The following is a description of a gene set: The chemical reactions and pathways involving glycoproteins, a protein that contains covalently bound glycose (i.e. monosaccharide) residues; the glycose occurs most commonly as oligosaccharide or fairly small polysaccharide but occasionally as monosaccharide. studied in species Homo sapiens Human Gene Set: GOBP_GLYCOPROTEIN_METABOLIC_PROCESS, and this is the list of marker genes: CHST2, APCS, MGAT1, GALNT15, B3GNT2, ALG10B, GLCE (glucuronic acid epimerase), ST6GALNAC5, ITM2B (integral membrane protein 2B), DDOST, B3GALT5, FBXO44, B4GALT2, MIR153-1, BACE2, MAN1B1, GCNT2, POGLUT1, CYTL1, MAN1A2, IGF1, RNF5, TMEM165, HEXA, AGO2, GMPPA, CTNNB1, ITM2A, MPDU1, ALG2, EDNRA, RPN2 (NCBI Gene Id 6185), BMPR1B, PTX3, CHST14, FUT8, EXT2, ST8SIA5, ALG10, ST3GAL4, ACOT8, CHST7, C20orf173, MAN2A1, DOLK, PRKCSH, B3GALT1, CRPPA, GALNT17, MARCHF6, B3GNT9, PGM3, NECAB1, NEU2, MOGS, MGAT4C (NCBI Gene Id 25834), B4GALT6, ST6GAL1, RFT1, HGSNAT, NAGLU, CHP1 (NCBI Gene Id 11261), UGGT2, CANT1, ARFGEF1, MIR101-1, DOLPP1, MIR144, MUSTN1, DPY19L1, ALG3, B4GALT5, GCNT7, ST8SIA3, TET2, TRIP11, CHSY3, XYLT1, GALNT5, FUT5, PLOD3, ST3GAL6, B3GNT3, GANAB, ABCA2, ST3GAL3, GALNT9 (polypeptide N-acetylgalactosaminyltransferase 9), POMGNT2, B3GNT7, GCNT4, TM9SF2, CELA1 (chymotrypsin like elastase 1), NGLY1, ALG11, GALNTL6, NCSTN, GALNT13, MAN1A1, ENGASE, CCDC134, C1GALT1C1, TMEM106A, ST8SIA4, ST6GALNAC1, B3GNT8, CHST1, HS3ST5, POMT2, POGLUT2, FBXO6, DERL3, GALNT3, B3GALT4, RAB1A, DPM1, TMTC1, NCCRP1, GALNTL5, TET3, PPARD (peroxisome proliferator activated receptor delta), MANBA, ALG12, BMP2, MIR147A, MGAT4A, UST, B3GAT2, RPN1, MIR520C, CHST13, B4GALT7, CHST6, MMP12, FUT7, GALNT7, GALNT18, HIF1A, HS6ST1, GALNT6, IHH, FBXO2, NUS1, TNIP1, ADAMTS12, FREY1, ST6GALNAC3, ADAMTS4, XXYLT1, B3GALT9 (NCBI Gene Id 402377), FKTN, PXYLP1, SRD5A3, NUDT14, TUSC3, MIR644A, GLB1, EXT1, ALG6, LEP, FUT11, B3GAT3, AGA (NCBI Gene Id 175), EDEM1, TMEM59, A4GNT, GANC, GATA1, POFUT2, B4GAT1, B3GNT5, GPC1, FUT6, GCNT1, PMM2, FUT4, MGAT4D (MGAT4 family member D), TMTC4, SLC2A10, B4GALNT2, DHDDS, EDNRB, MIR20A, DPAGT1, ANGPT1, ST3GAL2, B4GALT1, GOLPH3, CHSY1, SLC34A1, EDEM3, MGAT4B, BTK, FUT10, TRAK1, ALG14, KRTCAP2 (NCBI Gene Id 200185), TMEM260, TRAK2, UBE2J1 (NCBI Gene Id 51632), ST6GALNAC4, GMPPB, TCF7L2, SULF1, NECAB2, PLCB1, POFUT1, GCNT3, GALNT4, FOXL1, XYLT2, MIR17, NDST2, SYVN1, LARGE1, TRIM13, PCSK6, COG3, RXYLT1, PLOD2, B3GALT6, HPSE, HS3ST6, CCR7, GALNT8, COG7, GXYLT1, SULF2, HS3ST3B1, GOLGA2, CHST9, EXTL3, NDST1, CSGALNACT2, GAL3ST2 (galactose-3-O-sulfotransferase 2), MIR455, B3GALT2, RAMP1, CHPF (NCBI Gene Id 79586), PMM1, MGAT2, GNPTAB (NCBI Gene Id 79158), POMT1, IL33, TMTC2, TMTC3, ST3GAL1, SERP1, B3GNT6, MAN2A2, SLC35C2, RNF103, SLC35D2, GALNT14, RAB1B, FBXO27, CTSL, NAGPA, CSGALNACT1, CHST11, MGAT5B, ALG9, HS6ST3, SGSH, HS2ST1, HS3ST4, UGGT1, ST6GALNAC2, GALNT12, MIR31, MAN2B1, FUT3, IDS, NDST4, B4GALT3, RNF139, GFPT1, BMPR2, FUT2, MAGT1, MFSD8, GAL3ST1, FUT9, B3GALNT2, GNPTG, NPC1, CHST8, LARGE2, EXTL2, HS6ST2, CHST5, ADAMTS7, B3GALNT1, MIR323A, OSTC, POMK, HYAL1, VEGFB (NCBI Gene Id 7423), ITM2C, HS3ST1, PAWR, STT3A, MIR181B1, ST6GAL2, DPM3, ALG5, GAL3ST3, ERP44, PORCN (porcupine O-acyltransferase), GALNT2, CST3, PSEN1, CHPF2, MIR298, ACER2, TMEM258, ST8SIA6, CWH43, ALG8, GNS, ST8SIA2, ATP7A, CNMD, DPM2 (dolichyl-phosphate mannosyltransferase subunit 2, regulatory), ABO, GALNT16, MAN1C1, CCL21, DAD1, FAM20B, GFPT2, EXTL1, ST6GALNAC6, SLC10A7, BCL2, B3GLCT, CHST4, POGLUT3, SOAT1, VANGL2, OGT, EDEM2, OGA, GALNT1, CHST3, COL11A1, DPY19L3, AQP11, NEU4, DSEL, GBGT1, EOGT, HS3ST3A1, ALG1L2, IDUA, UGDH, FUT1, GORASP1, ALG1, COL2A1, SLC35B2, HS3ST2, COLGALT1, AMFR, B4GALT4, GUSB, GXYLT2, CHST12, ST3GAL5, OST4, MGAT5, FKRP, MGAT3, ADAMTS13, PLOD1, ENTPD5, DSE, GALNT10, MIR106A, GAL3ST4, CCL19, B3GAT1, RNF185, C1GALT1, ST8SIA1, NECAB3, HYAL4 (NCBI Gene Id 23553), STT3B, ALG13, NDST3, AATF, CHST10, SLC39A8, LMF1 (NCBI Gene Id 650392), TET1, POMGNT1, ABCA7, FBXO17, B3GNT4, HEXB, SLC51B, GALNT11, JAK3